Given this list of marker genes LPL, SREBF2, CD36, SCARB1, MIR144, APOB, MSR1, EHD1, here is a description of the gene set: Any process that increases the rate or extent of cholesterol storage. Cholesterol storage is the accumulation and maintenance in cells or tissues of cholesterol, cholest-5-en-3 beta-ol, the principal sterol of vertebrates and the precursor of many steroids, including bile acids and steroid hormones. species: Homo sapiens Human Gene Set: GOBP_POSITIVE_REGULATION_OF_CHOLESTEROL_STORAGE